The following is a description of a gene set: studied in species Homo sapiens Human Gene Set: GOBP_POSITIVE_REGULATION_OF_CELL_ADHESION_MEDIATED_BY_INTEGRIN Any process that activates or increases the frequency, rate, or extent of cell adhesion mediated by integrin., and this is the list of marker genes: SYK, RET, CCL21, P2RY12 (NCBI Gene Id 65213), ADAM9, FOXC2, IFT74, CD3E, PODXL, NCKAP1L, LIF, PTPN6, RAC3, ITGB3, FERMT1, SFRP2, PIEZO1, CIB1, CCL5, TGFB2, SKAP1 (NCBI Gene Id 8631), CXCL13